The following is a description of a gene set: Following activation, AKT can phosphorylate an array of target proteins in the cytoplasm, many of which are involved in cell survival control. Phosphorylation of TSC2 feeds positively to the TOR kinase, which, in turn, contributes to AKT activation (positive feedback loop). species: Homo sapiens part of: PIP3 activates AKT signaling Reactome Pathway: AKT phosphorylates targets in the cytosol, and this is the list of marker genes: AKT1, GSK3A, AKT2, AKT3, AKT1S1, CDKN1A, MKRN1, CDKN1B, GSK3B, MDM2, TSC2, CASP9, CHUK, BAD